Given this list of marker genes Hras, Elk1 (ELK1, member of ETS oncogene family), Ptk2, Rapgef1, Grb2, Src, Rasa1 (NCBI Gene Id 218397), Crkl, Map4k1, Fos, Pak1, Mapk3, Pik3ca, Sos1, Gab1, Map2k2, Mapk8, Itgb1, Stat3 (signal transducer and activator of transcription 3), Itga1, Ptk2b, Dock1, Pten, Ptpn11, Hgf, Met, Jun, Rap1a, Pxn, Map2k1, Rap1b, Crk, Raf1, Mapk1, here is a description of the gene set: Hepatocyte growth factor receptor signaling Mouse Gene Set: WP_HEPATOCYTE_GROWTH_FACTOR_RECEPTOR_SIGNALING species: Mus musculus